The following is a description of a gene set: RIG-I-IRF7/3 signaling pathway. Pathway ID: N00469. Pathway type: Reference. Pathway class: nt06519 RLR signaling. studied in species Homo sapiens Human Gene Set: KEGG_MEDICUS_REFERENCE_RIG_I_IRF7_3_SIGNALING_PATHWAY Pathway Definition from KEGG: RNA -> RIGI -> MAVS -> TRAF3 -> (TANK+NAP1+SINTBAD) -> (TBK1+IKBKE) -> (IRF7,IRF3) => (IFNA,IFNB1), and this is the list of marker genes: TBKBP1, IFNA6, IKBKE, TBK1, IFNA21, IRF7, IFNA5, IFNA16, IRF3, TRAF3, IFNA7, IFNA4, IFNA14, IFNA8, IFNB1 (interferon beta 1), AZI2 (5-azacytidine induced 2), TANK, MAVS, IFNA17, IFNA10, IFNA2, IFNA13, RIGI, IFNA1